The following is a description of a gene set: Any process that modulates the rate, frequency, extent of the regulated release of somatostatin from secretory granules in the D cells of the pancreas. Mouse Gene Set: GOBP_REGULATION_OF_SOMATOSTATIN_SECRETION studied in species Mus musculus, and this is the list of marker genes: Sct, Ffar4, Cckbr, Cacna1e, Cckar, Irs1, Adcyap1